Given this list of marker genes Amdhd1, Uroc1, Ftcd, Carns1, Hal, Hdc, Carnmt1, here is a description of the gene set: species: Mus musculus Mouse Gene Set: REACTOME_HISTIDINE_CATABOLISM Histidine catabolism